Given this list of marker genes Ccl21a, Cd28, Ccl19, Cd160, Tnfsf4, Lgals8, Cav1, Ccr7, Efnb2, Cd274, Ephb4, Spn, Cd86, Tnfrsf13c, Lilrb4b, Tnfsf13b, Il4, Card11, Cd5, Tnfrsf14 (tumor necrosis factor receptor superfamily, member 14 (herpesvirus entry mediator)), Cd81, Cd24a, Vav1, Tnfsf14, Cd3e, Icos, Efnb3, Lgals1, Cd80, Cd320, Efnb1, Dpp4, Lilrb4a, Pdcd1lg2, Ephb6, here is a description of the gene set: Mouse Gene Set: GOBP_LYMPHOCYTE_COSTIMULATION The process of providing, via surface-bound receptor-ligand pairs, a second, antigen-independent, signal in addition to that provided by the B- or T cell receptor to augment B- or T cell activation. studied in species Mus musculus